The following is a description of a gene set: Human Gene Set: GSE3039_B2_VS_B1_BCELL_UP Genes up-regulated in B lymphocytes: B2 versus B1. Three innate (B1-B, NKT, CD8aaT cells) and adaptive (B2-B, CD4T, CD8abT cells) cell-types were sorted by FACS. Three biological replicates for NKT, CD4T, CD8aaT, CD8abT cells and two biological replicates for B1 and B2 cells were generated and the expression profiles were determined using Affymetrix Mu74Av2 chip. Comparisons between the sample groups allow the identification of genes differentially expressed between the innate and adaptive cell-types. species: Homo sapiens from publication Yamagata T, Benoist C, Mathis D (PMID 16623764), and this is the list of marker genes: TMEM245, ISG20, PLPP1, CD1D, TMEM35B, ABCA1, FOXN3, KCNJ8, ZFP36, SPIRE1, SFT2D1, FKBP7, TGFBR3, IFIT1, LAX1, SULF2, PTGIS, CCL24, TNFRSF1A, STAB2, STK32C, MCL1, PDGFC, SGSH, SHFL, GIMAP1, OXSM, TMEM176A, ITGB3, SLC22A23, DOCK4, PRKAB2, SLAMF8, SLC15A2, AP3M2, UBD, RAB11FIP2, SLU7, ADGRA2, BCL10, CD163, INPP5K, SLC16A9, AGRN, CD79A, TBC1D9, JUNB, TSTD1, B4GALT4, VPS16, STK10, DENND4A, HOOK3, IFI30, APOBEC1, SLC25A37, ZNF229, IFI27, CCRL2, SEC14L1, SCD, MRAP, ADD3, UBE2L6, PHLPP1, HES1, MYO9A, SLPI, TIFA, PILRB, USP3, RYR3, CFAP141, HCK, ASAH1, PRR5L, CALML4, MARCO, SHISA5, NR1H3, CRIM1, NRIP1, NRM, C5orf22, FARP2, GALNT1, CYTH3, SPICE1, SNCA, UIMC1, STARD5, MFSD9, IFT172, MGST1, IMMP2L, DDX23, RASGRP3, SLAMF7, EEF2K, MAP3K5, ZBTB41, GIMAP4, IRGM, CYTIP, PREB, PATJ, PLAGL1, SIPA1L1, CCDC186, RASGRP2, ZNF467, ERLIN1 (NCBI Gene Id 10613), SELENOM, ARHGAP26, ACP2, C3orf33, IL18R1, TNFRSF14, CCND1, SYCP2, GRAMD1C, AVPI1 (arginine vasopressin induced 1), KRIT1, FOXO1, NAT8L, IKZF2, MPZL3, ALAS2, SELPLG, CHD3, TSPAN3, ATM, TRIP6, TLR8, BTG1, ACE, SCRG1 (NCBI Gene Id 11341), BBX, CD40, PDE7A, GM2A, KLRC1, TXNDC16, SLC8A1, STXBP6, PIK3IP1, TUBB2B, NR4A1, ENPP4, CXCR2, KIF21B, DCLRE1C, HEBP1, SLC25A31, ETV1, ARFIP1, GLIPR1, NCR1, GNG2, ITGA9, ZKSCAN1, PHC1, AKAP11, FRAT1, STX17 (syntaxin 17), CLEC4M, MDM1, VSTM4, GLCCI1, CREBRF, PHLPP2, DIPK2A, PRG4, INPP4B, MZB1, CX3CR1, KBTBD11, AKR1B10, LMNB1, ATF6 (activating transcription factor 6), CKB (creatine kinase B), PALS1, HLA-DOA, AHSP, RIMS3, HRH1, PIGL, ZNF12, ARL15, CEP290 (NCBI Gene Id 9707), GDI2, TMEM176B, CXCR5, BMP2, SFXN2, FBRSL1, AKAP9, CIITA, SLC4A1